Given this list of marker genes B9D2, NSL1, CENPI, TUBA3D, CLASP2, CENPL, PMF1, FIRRM, TUBB6, DYNC1LI2, MIS12, PAFAH1B1, SKA1, TUBB8, TUBB2A, TUBB4A, DYNLL2, NUF2, DYNC1LI1, BUB3, CLASP1, SGO2, INCENP, SMC3, XPO1, CENPN, STAG1, SEC13, PDS5B, SMC1A, CENPP, NUP85, PPP1CC, KNL1, CENPS, NUP107, SPC24, PLK1, CENPE, TUBA1A, PPP2R5B, RPS27, NUP43, PPP2R1A, ZW10, TUBA4B, TUBA3C, TUBA1B, CENPU, CENPO, NDE1, ZWILCH, CDK1, CENPQ, NDC80 (NDC80 kinetochore complex component), PPP2R5C, MAPRE1 (microtubule associated protein RP/EB family member 1), ITGB3BP, NUP98, TUBA3E, CCNB1, PPP2R5A, TUBB8B, AHCTF1, PPP2R1B, NUDC, TUBB2B, PPP2CA, NUP160, SGO1, CCNB2, CLIP1, MAD2L1, TUBB3, NUP133 (NCBI Gene Id 55746), BUB1B, PPP2CB, CDC20, ERCC6L, SKA2, DYNC1I1, ZWINT, SEH1L, TAOK1, KIF2A, KIF2C, CKAP5, TUBA1C, NDEL1 (NCBI Gene Id 81565), TUBA8, KIF18A, BUB1, MAD1L1, RAD21, STAG2, TUBA4A, CENPC, CENPH, CDCA5, DYNLL1, CENPF, RANGAP1, SPDL1, CDCA8 (NCBI Gene Id 55143), DYNC1H1, CENPA, DYNC1I2, KIF2B, TUBAL3, SPC25, CENPM, PPP2R5D, TUBB1, KNTC1, DSN1, CENPT, NUP37, WAPL, PPP2R5E, HDAC8, CENPK, RANBP2, TUBB4B, PDS5A, AURKB, BIRC5, RCC2 (regulator of chromosome condensation 2), here is a description of the gene set: species: Homo sapiens Reactome Pathway: Resolution of Sister Chromatid Cohesion part of: Mitotic Prometaphase The resolution of sister chromatids in mitotic prometaphase involves removal of cohesin complexes from chromosomal arms, with preservation of cohesion at centromeres.<br><br>CDK1-mediated phosphorylation of cohesin-bound CDCA5 (Sororin) at threonine T159 provides a docking site for PLK1, enabling PLK1-mediated phosphorylation of cohesin subunits STAG2 (SA2) and RAD21. Further phosphorylation of CDCA5 by CDK1 results in dissociation of CDCA5 from cohesin complex, which restores the activity of WAPAL in removing STAG2-phosphorylated cohesin from chromosomal arms.<br><br>At centromeres, kinetochore proteins shugoshins (SGOL1 and SGOL2) enable PP2A-B56 (also a kinetochore constituent) to dephosphorylate the STAG2 subunit of centromeric cohesin. Dephosphorylation of STAG2 enables maintenance of centromeric cohesion, thus preventing separation of sister chromatids until anaphase.